The following is a description of a gene set: Genes up-regulated in comparison of peripheral blood mononuclear cells (PBMC) from patients with acute influenza infection versus PBMC from patients with acute S. pneumoniae infection. Each infectious agent represents a unique combination of pathogen-associated molecular patterns that interact with specific pattern-recognition receptors expressed on immune cells. Therefore, we surmised that the blood immune cells of individuals with different infections might bear discriminative transcriptional signatures. Gene expression profiles were obtained for 131 peripheral blood samples from pediatric patients with acute infections caused by influenza A virus, Gram-negative (Escherichia coli) or Gram-positive (Staphylococcus aureus and Streptococcus pneumoniae) bacteria. Thirty-five genes were identified that best discriminate patients with influenza A virus infection from patients with either E coli or S pneumoniae infection. These genes classified with 95% accuracy (35 of 37 samples) an independent set of patients with either influenza A, E coli, or S pneumoniae infection. A different signature discriminated patients with E coli versus S aureus infections with 85% accuracy (34 of 40). Furthermore, distinctive gene expression patterns were observed in patients presenting with respiratory infections of different etiologies. Thus, microarray analyses of patient peripheral blood leukocytes might assist in the differential diagnosis of infectious diseases. from publication Ramilo O, Allman W, Chung W, Mejias A, Ardura M, Glaser C, Wittkowski KM, Piqueras B, Banchereau J, Palucka AK, Chaussabel D (PMID 17105821) species: Homo sapiens Human Gene Set: GSE6269_FLU_VS_STREP_PNEUMO_INF_PBMC_UP, and this is the list of marker genes: USP18, SPATS2L, PTPRC, UBE2D4, PARP2, SMG7, N4BP1 (NCBI Gene Id 9683), PPIG, USP1, JUP, ISG15, IDH2, HACD3, NF1, HEG1, CKS2, PARP12, KPNB1, RUSF1, OAS2, UBXN4, IFITM2, HMGXB3, ABL1, HELLS, PHF11, DTX2P1-UPK3BP1-PMS2P11, IL2RG, PTMA, EIF2AK2, IFITM3P7, RSAD2, CEP290, HERC5, OARD1, REC8, TAF1B, SHFL, CHD4, ACTN4, GART, RAD51C, EIF5B, AKAP1, CMTR1, IFIT1, SON, KCTD14, GPATCH8, DDX60, ERGIC2, MAP4, GLYR1, COX8A, SP110, OASL, HLA-B, HMMR, SPDL1, ZNF609, AASDHPPT, OAS3, TMEM255A, PSME2, LGALS3BP, MED24, NAA35, PRPF40A, ESF1, EIF4G1, NAA15, NMI, ST3GAL5, BPTF, SLC25A11, XAF1, RPL28, SERPING1, NXF1, SYNCRIP (synaptotagmin binding cytoplasmic RNA interacting protein), MLEC, RFWD3, SMG1, PRR5, SMARCA4 (SWI/SNF related, matrix associated, actin dependent regulator of chromatin, subfamily a, member 4), PARP11, GMIP, IFITM3, TGS1, CALR, TRAPPC4, PURA, HLA-E, RORA, IFI35, PHACTR2, RBM25, TYMP, SART3, IFI6, STIL, LY6E, THOC2, PDHX, ZNF264, NFATC2IP, IFI16, HLA-A, SIGLEC1, AP3D1, PABPN1, MRPL42, CHST12, DDX24, WDHD1, GLG1, RTP4, GBP1, MED15, HLA-F, TRIM22, IFI44, ADAR, IFITM1, SBF1, MED1, CXCL11, DESI2, RHBDD3 (NCBI Gene Id 25807), SCAF11, CHMP5, ZBP1, PSMB9, TRANK1, DCAF15, TNIK, COIL, ILF3, MARK2, HERC6, SETX, IFIT3, KMT2A, ZWILCH (NCBI Gene Id 55055), DDX39B, POM121, PML, C2CD3, OAS1, IFI44L, BRD2, NUP62, NCOA3, YPEL1, IRF9, PPID, STAT1, IL12RB1, TRIM14, MX2, MIR3648-1, UBE2L6, IFIH1, CD2AP, ADA, MX1, DDX11, IRF7, GCH1, MKLN1